Given this list of marker genes MAN2A2, MGAT4B, CHST8, ST8SIA2, FUCA1, ST8SIA3, MGAT3, B4GALT5, ST6GAL1, FUT3, FUT8, MAN2A1, ST3GAL4, ST8SIA6, MGAT4A, B4GALT6, B4GALT1, MGAT2, B4GALT3, MGAT4C, B4GALT4, CGA, LHB, B4GALT2, MGAT5, CHST10, here is a description of the gene set: Human Gene Set: REACTOME_N_GLYCAN_ANTENNAE_ELONGATION_IN_THE_MEDIAL_TRANS_GOLGI N-glycan antennae elongation in the medial/trans-Golgi studied in species Homo sapiens